Given this list of marker genes SWSAP1, CD79A, ANKRD10, PNKD, ZNF558, CXCR3, CCDC191, UBR7, MLH1, MCM7, ZNF514, ANAPC5, CD19 (NCBI Gene Id 930), PRKAB2, CDR2, LRP5L, ECHDC2, HERC2 (NCBI Gene Id 8924), CCDC24, TRMT10B, MRPL49, ABCF2, DHCR7, CARMIL2, here is a description of the gene set: Human Gene Set: FRANCO_BLOOD_SANOFI_PASTEUR_SA_INACTIVATED_INFLUENZA_VACCINE_CORRELATED_WITH_ANTIBODY_RESPONSE_AGE_18_40YO_14DY_POSITIVE from publication Franco LM, Bucasas KL, Wells JM, Niño D, Wang X, Zapata GE, Arden N, Renwick A, Yu P, Quarles JM, Bray MS, Couch RB, Belmont JW, Shaw CA (PMID 23878721) studied in species Homo sapiens Genes positively correlated with antibody response in blood in adults (18-40) after exposure to Sanofi Pasteur, SA, Inactivated influenza vaccine, time point 14D Identification of the host genetic factors that contribute to variation in vaccine responsiveness may uncover important mechanisms affecting vaccine efficacy. We carried out an integrative, longitudinal study combining genetic, transcriptional, and immunologic data in humans given seasonal influenza vaccine. We identified genes exhibiting a transcriptional response to vaccination, significant genotype effects on gene expression, and correlation between the transcriptional and antibody responses. The results show that variation at the level of genes involved in membrane trafficking and antigen processing significantly influences the human response to influenza vaccination. More broadly, we demonstrate that an integrative study design is an efficient alternative to existing methods for the identification of genes involved in complex traits. DOI:http://dx.doi.org/10.7554/eLife.00299.001.